Given this list of marker genes RRP36, SLC22A5 (NCBI Gene Id 6584), UTP6, IFNGR1, ERAP1, ANAPC11, FCF1, SLC12A2, TET1, ZNF260, TMEM70, USP38, ATP5F1B, DRG2, SPRYD4, FEN1, ATP10A, TTLL12, TBL1X, GID4, ZC3HAV1, EMC10, MNAT1, MEX3B (mex-3 RNA binding family member B), RPA3 (NCBI Gene Id 6119), KCTD3, SIRT1, ABHD14A, TRIM44, PGGT1B, B3GLCT, TMTC4, GLRX3, RLIM, PUS7, NDUFA9, SLC35B4, TNRC6C, CRYZ, RBBP4, BLVRA, BMAL1, LTA, SOCS1, PPCS, AP3M2, DOCK2, OTULIN, NKRF, PRORP, LGALS1, UBAP2, MDP1, METTL15, ST13, NTHL1, HMG20A, RPL31, INO80E, EREG, GNPTG, STYX, MRPL3, TAPT1, CEP57L1, MTRF1L, POLR2J, IPP, MRPL41, ATPAF1, FLNB, LDB1 (LIM domain binding 1), METTL3, C10orf88 (NCBI Gene Id 80007), PHGDH, GZMB, SETDB2, FAM118A, SNRNP200, PTPN21, MAP4K1, NXF1, DIPK1A, ACAD9, NUDT2, FPGT, GNL2, IMMP1L, LCMT2, NAB2, TMEM241, IFT46, HELB, ARF6, SRSF11, PIGA, PIGY, CAB39L, COQ6, CEBPZ, APOOL, RHEBL1, TRIB2 (NCBI Gene Id 28951), VWCE, MRTFB (myocardin related transcription factor B), GFUS (NCBI Gene Id 7264), BOP1, UQCC6, PARS2, SLC35A4 (solute carrier family 35 member A4), SHMT1, GSTO1, ACOXL, CAPRIN1, SYNJ2BP, SMAD7, PTGIS, DHCR7, ZFP90 (NCBI Gene Id 146198), HOOK1, SDF4, KANSL3, HPCA, EIF2B3, RIMOC1 (NCBI Gene Id 285636), PDXP, SUPT20H, BUD23, EIF2S2, EIF2B4, SPATA6, NDRG3, POGLUT2, SENP3, LETM1, TRA2B, SMAD4, BCL9L, RPAIN, ZNF598, NGDN, YIPF5, PHF20, GBP7, ACAA2, IMP4, POP7, TAP1, IKBKB, STIP1, TUBGCP5, SETD2, TUBGCP2, EMC4 (ER membrane protein complex subunit 4), CUL1, PTPN2, MRPL34, TUT4, TRIM35, CCDC82 (NCBI Gene Id 79780), ZDHHC21, ZNF622, EIF4A2, ZC4H2 (NCBI Gene Id 7493), MRPL46, RNF2, SLC37A4, GPAM, HNRNPH1, PAK1IP1, EXT1 (exostosin glycosyltransferase 1), SLC25A19, GTF2F2, AMMECR1L, SMG1, RAD1, POLR1H, DRG1, TSR3, DDX24, TRIM27, CHRNA4, BST2, ERCC5, RBCK1, FGF17, NOL8, PHF6, FAM162A, C2orf76, SMARCB1, TARS2, CTDNEP1, THAP7, NMI, TAF4B, ANAPC16, ARB2A, CCAR1, here is a description of the gene set: Each fraction of mouse hematopoietic cells was purified by cell sorting from bone marrow of 8-week-old C57BL/6 mice, and its gene expression was analyzed. Human Gene Set: GSE27786_CD8_TCELL_VS_NEUTROPHIL_UP from publication Konuma T, Nakamura S, Miyagi S, Negishi M, Chiba T, Oguro H, Yuan J, Mochizuki-Kashio M, Ichikawa H, Miyoshi H, Vidal M, Iwama A (PMID 21540074) Genes up-regulated in comparison of CD8 T cells versus neutrophils. studied in species Homo sapiens